The following is a description of a gene set: Human Gene Set: GOBP_POSITIVE_REGULATION_OF_HEMOPOIESIS Any process that activates or increases the frequency, rate or extent of hemopoiesis. studied in species Homo sapiens, and this is the list of marker genes: CCR1, SASH3, MIR21, RIPK2, RHOA, IL21, SMARCC1, IL36B, IL2RG, ACIN1, IL23R, ID2, GATA3, SOCS1, MMP14, HLA-G, IL15RA, CTNNBIP1, BRD4, NKAP, BCL6, IL20, ZAP70, RUNX1, CD101, FOS, POU4F2, CD80, LILRB4, CD74, BTK, EP300, TM4SF19, ANXA1, IL5, CYLD, RB1, FOXO3, IL7R, IL18, RARA, CD83, PRKCZ, SOX4, RAG1, CD46, ARID2, SMARCD1, IL2, BRD7, ZBTB1, IL15, IFNG, DCSTAMP, LEF1, SMARCD3, LGALS9, GLI2, DDRGK1, EVI2B, PCID2, INPP5D, ARID1B, IL34, SYK, MIR145, IL23A, CREB1, NEDD9, CASP8, SOX13, EGR3, FADD, DUSP10, OPA1, SMARCD2, NFKBIZ, PHF10, SLC9B2, TNFSF11, RUNX3, IL12RB1, TNFSF4, PF4, KLF10, MDK (midkine), WNT10B, TRIB1, HMGB1, IHH (Indian hedgehog signaling molecule), NFKBID, ACTL6A, IL1RL2, PPARGC1B, NLRP3, ACTL6B, AP3D1, LILRB2, SMARCB1, XRCC6 (X-ray repair cross complementing 6), CD4, ZBTB46, LCK, XBP1, SOX12, STAT5B, ADAM8 (ADAM metallopeptidase domain 8), TGFB1, TNF, PPP3CA, PRKCA, HAX1 (HCLS1 associated protein X-1), IL4R, GPR68, CD86, GAS6, LGALS3, RASGRP1, HLA-DRB1, IL10, CALCA, IL7, ADA, TOX, PPP2R3C, IL2RA, AMBRA1, NCKAP1L, KAT5, SHB, SHH, ZFP36L1, RIPK1, CCL19, AXL, SMARCA4, TRAF6, PLA2G3 (NCBI Gene Id 50487), BTN2A2, IL4, POU4F1, OCSTAMP, KITLG, EEIG1, TGFBR2, GLI3, FOXP3, PNP, TYROBP, BRD2, LIF, MALT1, ARID1A, TMEM64, ZBTB7B, TNFRSF11A, RHOH, CSF1, HCLS1, TREM2, NOTCH2, CR1, TESPA1, STAT5A, PBRM1, SART1, CD27, SPI1, TESC, SMARCA2, TNFSF9, HLA-DRA, HLX (H2.0 like homeobox), AP3B1, VNN1, ZMIZ1, PTPRC, ZBTB16, SOCS5, KLHL25, RPTOR, MIR486-1 (microRNA 486-1), ACTB, AGER, PIK3R6, IL17A, ITPKB, FES, GPR65, LGALS1, BAD, IL4I1, CBFB, PCK1, VSIR, HSF1, SMARCE1, SMARCC2, IL12B (interleukin 12B), PRKDC